Given this list of marker genes TRBV24-1, TRBV6-4, TRAV8-2, TRAV16, TRBV11-1, TRAV19, TRBJ1-3, TRDV3, TRBV12-3, TRAV1-1, ALCAM, TRAV4, CD8B, TRBJ2-6, TRGC1, TRAV21, TRDJ1, TRAV39, TRBV4-1, TRBV9, TRAV6, TRGV9, TRAV9-1, TRAV5, TRBV6-1, TRBJ1-5, TRBV27, TRBV25-1, TRAV8-3 (NCBI Gene Id 28683), TRAV10, TRBV6-7, TRBV5-6, TRBV28, TRBV20-1, TRAV7, TRBV4-2, SYK, TRAV13-1, TRDV2, TRBV29-1, TRAV41, TRAC, TRBV7-3, TRAV8-1, TRBV3-1, TRBD1, TRAV12-3, TRBV14, ZAP70, TRAV34, TRBJ1-1, TRBV7-6, CD3D, TRBV30, TRGV11, TRBV23-1, TRAV20 (NCBI Gene Id 28663), CD8A, TRAV38-2DV8, CEACAM1, TRBV7-7, TRBC1, TRAT1, TRAV27, TRDV1, TRGV4, TRBJ1-4, TRGV8, TRAV9-2, TRBV5-7, TRBV7-4, TRAV8-4, CD3G, CD6, TRAV26-1, TRAV35, TRAV12-1, SKAP1, TRBC2, TRGV3 (T cell receptor gamma variable 3), TRAV2, TRAV14DV4, TRBV7-1, TRAV30, TRBV5-5, TRBJ2-3, TRBV18, TRGC2 (T cell receptor gamma constant 2), APBB1IP, TRBV12-5, CD4, TRAV18, TRBV13, TRBJ2-4, TRAV29DV5, TRGV5, TRBV2, TRGV2, TRBV12-4, TRBV6-5, TRBV5-1, TRBV11-2, TRBV19, CD247, TRBV5-3, TRAV3, TRGV1, TRAV25, TRAV26-2, TRBJ1-6, TRGV10, TRBV11-3, TRBV16, TRAV23DV6, TRBV5-4, TRBV6-8 (T cell receptor beta variable 6-8), TRAV17, TRBV7-2, TRAV12-2, TRBJ2-2, TRBJ2-7, TRAV1-2, TRAV36DV7, CD3E, TRAV22, TRAV40, TRBV7-9, PTPN6, TRBJ2-1, TRBV10-1, TRDC, TRBV6-6, TRBV10-3, TRAV8-6, TRAJ3, TRDD1, TRBV10-2, TRAV13-2, TRAV24, TRBJ2-5, TRBJ1-2, TRAV38-1, TRBV17, here is a description of the gene set: Human Gene Set: GOCC_T_CELL_RECEPTOR_COMPLEX species: Homo sapiens A protein complex that contains a disulfide-linked heterodimer of T cell receptor (TCR) chains, which are members of the immunoglobulin superfamily, and mediates antigen recognition, ultimately resulting in T cell activation. The TCR heterodimer is associated with the CD3 complex, which consists of the nonpolymorphic polypeptides gamma, delta, epsilon, zeta, and, in some cases, eta (an RNA splice variant of zeta) or Fc epsilon chains.